Given this list of marker genes Hif1a, Nlrc3, Rap1gds1, Il1r2, Abcd2, Tlr3, Appl2, Lep, Il6, Stat3 (NCBI Gene Id 68733), Hmox1, Traf3ip2, Il17a, Cuedc2, Pld4, Tlr6, Apod, Extl3, Myd88, Nos2, Pla2g10, Il17f, Tlr4 (toll-like receptor 4), Pld3, Il17rc, Tarm1 (NCBI Gene Id 245126), Ezh2, Card9, Trem2, Mapk9 (mitogen-activated protein kinase 9), Lilrb4b, Ido1 (indoleamine 2,3-dioxygenase 1), Ankrd42, Prkca, Reg3g, Il17c, Sirpa, Gpsm3, Abcd1, Nod2, Pdcd4, Pla2g3, Alox5, Per1, Mapk14, Cd6, Mir324, F2, Ticam1, Chid1, Chrna7, Appl1 (adaptor protein, phosphotyrosine interaction, PH domain and leucine zipper containing 1), Kpna6, Macir, Gbp5, Ppara, Seh1l (SEH1-like (S. cerevisiae), Zc3h12a, Il22, Adcy7, Cd96, Pycard, Il17b, Il22ra1, Clec7a, Il17d, Ephb2, Bap1, Spink7, Il17ra, Tnf, Mefv, Itgb6, Lilrb4a, Jak2, here is a description of the gene set: Mouse Gene Set: GOBP_CYTOKINE_PRODUCTION_INVOLVED_IN_INFLAMMATORY_RESPONSE studied in species Mus musculus The synthesis or release of a cytokine following a inflammatory stimulus as part of an inflammatory response, resulting in an increase in its intracellular or extracellular levels.